The following is a description of a gene set: Human Gene Set: HOXD11_TARGET_GENES studied in species Homo sapiens from publication Yevshin I, Sharipov R, Kolmykov S, Kondrakhin Y, Kolpakov F (PMID 30445619) Genes containing one or more binding sites for (HOXD11) in their promoter regions (TSS -1000,+100 bp) as identified by GTRD version 20.06 ChIP-seq harmonization., and this is the list of marker genes: PIGO, DPP4, CCDC18, PRMT5-DT, DNAJB12, RNU11, ASAH1-AS1, SLC28A2-AS1, PDCD10 (NCBI Gene Id 9226), GPBP1L1, CCT6A, JKAMP, ARRB1, STAT6, PDK1, IFT122 (NCBI Gene Id 55764), PPP4R3B-DT, CALCOCO1, SUB1, ERAP1, RAB5A, ZNF280B, SND1-DT (NCBI Gene Id 121832805), PRMT5, MIR4638, PPP2CA-DT, CDKL3, ETF1, C16orf95-DT, JMY, SERPINI1, LAMTOR4, ZNF428, LINC00339, SAR1B, MGAT1, REX1BD, NDUFV3, MTHFS, DPH5, TMEM9B, PPP4R3B, MRPL57, WDR4, AFG1L, MPHOSPH10, NBR1, ZFYVE19, L3HYPDH, DNAJC17, GMNN, ELP1, TNPO1-DT, ATF7IP, FBXO24, PPP2CA, RPL30P11, TPRA1, ECSIT, WBP4, MCEE, TRUB2, TRIM41, MMAB, ASAH1, H4C1, TMEM242, TOB2, ZC3HAV1, ABITRAM, PIGO-AS1, MVK, OSBPL8, SNHG15, LIG1, HSD17B4, CATSPERG, COPA (COPI coat complex subunit alpha), MBD4, ALOX12B, TTC14-DT, NCSTN, FKBP14, GLUL, ATP10B, PSRC1, TMEM242-DT, LINC01635 (NCBI Gene Id 101928043), FSTL3, COQ7, SUCLG1, ATG5, COQ4, COQ7-DT, VDAC2, ORMDL1, TMEM9B-AS1, PRPF4, PXN-AS1, PMS1, RPUSD4, TAF6L, LRCH4, FMC1, PLK3, TMEM69, NDUFB2, CANX, MIR3661, UBE2B, TCHP, DYNLT1, FBXL17, NDUFB2-AS1, PSPH, CCDC18-AS1, AATF, TM2D1, ATP8B1, NOSIP, CAST, PLEKHA8, EFCAB5, ZSWIM9, SND1, HS3ST1, RPLP0, DTL, BSDC1, FAM118B, TACC1, ELF1, STAM2, SKA3, MCM2, LUC7L2, EFHB, DDR1, HAGH, SCAMP2, ENSG00000273523, RITA1, BRCA1, RPLP1, AMACR, GCHFR (NCBI Gene Id 2644), DHX8, TTC14, BAZ2A, TTLL4